Given this list of marker genes TBC1D10C, CCNB1, SPTLC1, STAT2, GPAM, ADRA1D, TXNDC11, RASGRP1, ANXA8, PGAM2, IL6R, CDCA2, LOXL3, KIF20A, MMP10, SCD, RXRG, TNFRSF21, PCSK5, PEX6, TACC3, CP, TMEM140, OASL, CERS4, TAF9B, UBE2T, NMI, GBP7, FAM83D, SCN4B, NEDD4, LRRC27, C1R, CKB, LIMCH1, PGAM5, ANKRD13C, PTGER3, TLN2, GCH1, WNT2, FADS3, TXNL4B, SMIM22, TRAIP, FAXDC2, TGFBI, PTN, DLGAP5, SLC24A5, TBL1X, REM2, FABP3, LIPE, DGKG, GNB4, CNR1, THBD, KRT23 (NCBI Gene Id 56668), TF, KNTC1, TOP2A, LRRC39, NUSAP1, IGSF1, PTTG1, KIF2C, UPK1A, CKLF, SERPINI1, ESPL1 (NCBI Gene Id 9700), CDO1 (cysteine dioxygenase type 1), RAB15, CDCA3, RD3L, EDN1, ACADM, GNA14, TNIK, CLDN11, PVALB, TBC1D19, C16orf54, E2F1, MOV10, GPD1 (NCBI Gene Id 2819), TAP1, NDUFA3, OSBPL6, FGF21, RAD51AP1, ARHGAP11A, CLMP, RACGAP1, SERPINE1, PSMB9, AQP7, TNNT1, PIMREG, ENKD1, PBK, PEX12 (NCBI Gene Id 5193), UBE2C, NDUFV3, TCEAL5, IL6, TNF, ZNF385B, TNFAIP6, CCL23, SP110, RTP4, CITED1, TGFB3, MBOAT2, NR1D1, SLC7A8, NEFM, PLAT, PKD2L2, CENPI, DNAJB2, ENDOD1, MMP3, RSAD2, HSD17B10, CD68, IMPACT (NCBI Gene Id 55364), VWA1, PDK4, IFIT2, VPS54, DTX3L, UQCRC2, VGLL2, UCP3, CDKN2C, CDC20, TNFRSF17, COASY, GCFC2 (GC-rich sequence DNA-binding factor 2), HPX, CPZ, KIF20B, UCP2, DGAT2, FXYD7, MBNL3, FGL2, KHK, IGSF10, CTXN1 (cortexin 1), SSTR2, PDK3, CDK1, FASN (NCBI Gene Id 2194), CPT1A, AASS, PFKFB4, NCALD, ANGPTL4, NID2, ACOT1, PARP14, ITGA8, SCLT1, ACADVL, CA4, NAT8L, ZNF23, ABCA1, SEPTIN4, RRM2, A2M, KRT6C, NDUFA2, SMIM15, SDC1, VPS13C, PPRC1, PFKM, KIF22, PPARGC1A, CCL2, UBE2L6, NDUFV2, DMAC2L, CROT, TGFBR3, MYH3, JAM2, OSBP, TIMP1, SPA17, MMP13, MKI67, CCNB2, NR4A3, OSBPL1A, CTSC, GBP2, NPY1R, UBA7, ENO3, AURKA, ACOT7, FNDC1, RIGI, ELOVL6, ARPP21, CPT1B, SEMA3D, FGF9, TNFSF9, CCL11, SLC30A2, LRPAP1, OAS1, IGFBP6, IFI35, ANK1, KRT7, CALCRL, PERM1, PENK, PGM2, B3GNTL1, CH25H, TMEM178A, AKAP12, PRC1, EPHA3, ALYREF, SLC37A4, TMEM164, PTPN6, TGFBR2, SERPINB2, GBP4, VLDLR, TRIM5, RASD2, HP, TMEM37, ELAVL2, EDNRB, SYBU, BSPRY, DECR1, CXADR, MASP1, ETNK1, SDCBP2, CCNE2, ATP5ME, NR4A1, RSPO3, SERPINB1, GPAT4, PARPBP, BUB1, GATM, OLR1, ABO, ECT2, LYPD8, ABHD3, TACSTD2, MME, LNX1, MERTK, HMGB2, ABCC9, SCOC, CEP128, TNFSF4, CKMT1B, SECISBP2L, CXCL10, MLYCD, ACSL3, AGPAT4 (1-acylglycerol-3-phosphate O-acyltransferase 4), SAPCD2, MX1, EIF2AK2, EPB41L3, S100A3, ACSS1, RBM47, LSR, HADHA, CMPK2, CD55, CKAP2, IFIT3, HUNK, FOXM1, IGFBP5, HERC6, CKMT2, CCNA2, GPX7, IRF7, PLK4, PSMB8, PEX11G, KNSTRN, AURKB, BEX4, DHX58, SLC2A3, PDCD4, BLNK, GLRX, THUMPD3-AS1, ACAD11, PHYH, FAM111A, UBE2QL1, NDUFB5, CENPT, CRB3, IRF6, RAPGEF5, THOC2, ASCC3, AXIN2, JADE1, NRTN, MYL9, BACE2, here is a description of the gene set: studied in species Rattus norvegicus Estrogen-related receptors (ERRs) play critical roles in regulation of cellular energy metabolism in response to inducible coactivators such as peroxisome proliferator-activated receptor gamma (PPARgamma) coactivator 1alpha (PGC-1alpha). A yeast two-hybrid screen led to the identification of the cytokine-stimulated transcriptional regulator, Bcl3, as an ERRalpha coactivator. Bcl3 was shown to synergize with PGC-1alpha to coactivate ERRalpha. Chromatin immunoprecipitation studies demonstrated that ERRalpha, PGC-1alpha, and Bcl3 form a complex on an ERRalpha-responsive element within the pyruvate dehydrogenase kinase 4 gene promoter in cardiac myocytes. Mapping studies demonstrated that Bc13 interacts with PGC-1alpha and ERRalpha, allowing for interaction with both proteins. Transcriptional profiling demonstrated that Bcl3 activates genes involved in diverse pathways including a subset involved in cellular energy metabolism known to be regulated by PGC-1alpha, ERRalpha, and a second nuclear receptor, PPARalpha. Consistent with the gene expression profiling results, Bcl3 was shown to synergistically coactivate PPARalpha with PGC-1alpha in a manner similar to ERRalpha. We propose that the cooperativity between Bcl3 and PGC-1alpha may serve as a point of convergence on nuclear receptor targets to direct programs orchestrating inflammatory and energy metabolism responses in heart and other tissues. Genes up-regulated in neonatal cardiac myocytes upon knockdown of BCL3 by RNAi. Human Gene Set: YANG_BCL3_TARGETS_UP from publication Yang J, Williams RS, Kelly DP (PMID 19451226)